The following is a description of a gene set: species: Homo sapiens Human Gene Set: GOBP_POSITIVE_REGULATION_OF_LYASE_ACTIVITY Any process that activates or increases the frequency, rate or extent of lyase activity, the catalysis of the cleavage of C-C, C-O, C-N and other bonds by other means than by hydrolysis or oxidation, or conversely adding a group to a double bond., and this is the list of marker genes: CACNA1D, EDNRA, CRHR1 (corticotropin releasing hormone receptor 1), GUCA1ANB-GUCA1A (NCBI Gene Id 118142757), ORAI1, CALCA, ADCYAP1, GNAS (NCBI Gene Id 82944), P2RY11, FXN, CACNA1C, CAP2, CAP1, GIPR, TMIGD3, ADORA3, STIM1, AVPR2, GUCA1A, ADORA2B, ACR, DRD5, GLP1R